The following is a description of a gene set: studied in species Homo sapiens Albinism Human Gene Set: HP_ALBINISM An abnormal reduction in the amount of pigmentation (reduced or absent) of skin, hair and eye (iris and retina)., and this is the list of marker genes: EPG5, HPS6, HPS5, HPS1, TYR, SLC45A2, HPS4, MITF, AP3B1, MC1R, DTNBP1, AP3D1, BLOC1S3, EDNRB, WDR45, OCA2, TYRP1, BLOC1S5, LRMDA, HPS3 (HPS3 biogenesis of lysosomal organelles complex 2 subunit 1)